Given this list of marker genes F2RL1, EDNRB, GJA5, F2R, SUCNR1, COMT, PCSK5, OR51E2, here is a description of the gene set: Human Gene Set: GOBP_RENAL_RESPONSE_TO_BLOOD_FLOW_INVOLVED_IN_CIRCULATORY_RENIN_ANGIOTENSIN_REGULATION_OF_SYSTEMIC_ARTERIAL_BLOOD_PRESSURE The physiological response of the kidneys to a decrease in blood flow. studied in species Homo sapiens